The following is a description of a gene set: part of: Metabolism of carbohydrates and carbohydrate derivatives electronically inferred by orthology from the curated human pathway Reactome Pathway: Glycogen metabolism studied in species Mus musculus This event has been computationally inferred from an event that has been demonstrated in another species.<p>The inference is based on the homology mapping from PANTHER. Briefly, reactions for which all involved PhysicalEntities (in input, output and catalyst) have a mapped orthologue/paralogue (for complexes at least 75% of components must have a mapping) are inferred to the other species., and this is the list of marker genes: Pygm (NCBI Gene Id 19309), Gbe1, Calm1, Phkg2, Ugp2